Given this list of marker genes POPDC3, ADRA2C, CYP2B6, EVA1B, VSIR (V-set immunoregulatory receptor), ADCYAP1, PERP, XPO7, EVA1A, PABPC4L, PDXP, SSBP2, F5, CA13, ARNT2, CDC14A, DRD2 (dopamine receptor D2), SLC16A12, FABP4, KCNAB1, NPR3, GPR153 (NCBI Gene Id 387509), HECW1, EPHB6, LOXL2, PDE6B (phosphodiesterase 6B), RIMS4, MED13, PLA2G7, CD74, LXN, RAB9B, SERPINE2, CD302, FGF9, EIF4G3, FBXO45 (F-box protein 45), QPCT, here is a description of the gene set: studied in species Mus musculus from publication Gaussmann A, Wenger T, Eberle I, Bursen A, Bracharz S, Herr I, Dingermann T, Marschalek R (PMID 17130830) The reciprocal chromosomal translocation t(4;11) is correlated with infant, childhood, adult and therapy-related high-risk acute leukemia. Here, we investigated the biological effects of MLL.AF4, AF4.MLL or the combination of both reciprocal fusion proteins in a conditional in vitro cell culture model system. Several parameters like cell growth, cell cycling capacity, apoptotic behavior and growth transformation were investigated under physiological and stress conditions. Co-transfected cells displayed the highest resistance against apoptotic triggers, cell cycling capacity and loss-of-contact inhibition. These analyses were complemented by gene expression profiling experiments and specific gene signatures were established for each of the three cell lines. Interestingly, co-transfected cells strongly upregulate the homeobox gene Nanog. In combination with Oct4, the Nanog homeoprotein is steering maintenance of pluripotency and self-renewal in embryonic stem cells. Transcription of Nanog and other stem cell factors, like Oct4 and Bmi1, was verified in biopsy material of t(4;11) patient cells which express both reciprocal t(4;11) fusion genes. In conclusion, the presence of both reciprocal MLL fusion proteins confers biological properties known from t(4;11) leukemia, suggesting that each of the two fusion proteins contribute specific properties and, in combination, also synergistic effects to the leukemic phenotype. Human Gene Set: GAUSSMANN_MLL_AF4_FUSION_TARGETS_D_UP Up-regulated genes from the set D (Fig. 5a): specific signature shared by cells expressing MLL-AF4 alone and those expressing both MLL-AF4 and AF4-MLL fusion proteins.